Given this list of marker genes LRRC75A, ATXN2L, SLITRK3, ENHO, ZNF704, UBFD1, SPECC1L, METTL16, ULK2, ETV6, FGD1, CHST7, AGPAT1, RPP14, GSTCD, JADE2, RBFOX1, PRX, LGR4, KCNA7, TESK2, RBM14, SOX11, ITGA5, SUGP1, PSME3, CSNK1G1, ARID5A, TTC38, RSBN1L, SERTAD2, HAP1, SNRK, YWHAZ, WDTC1, ARID4B, PIM1, MAX, ZNF423, FOXO4, UBE2Z, ESCO1, ASAP1, NR3C1 (nuclear receptor subfamily 3 group C member 1), DDX11, DNMT3A, PNCK, H4C4, DYNC1I1, SEPTIN3, MECP2, CADM4, SLC2A1 (solute carrier family 2 member 1), H2AX, PTPN9, ARL4C, PLCB1, NRP2, VSIG4, TTYH3, DPH2, SLC39A5, EDARADD, ASB15, ZC3H12B, ST20-AS1, AFF2, USP37, GPM6A, SIX4, NRIP1, SCN2B, FAM133B, DPYSL3, ESRRA, SHISA5, PLAG1, PAK6, ST3GAL3, RPS29, here is a description of the gene set: Genes having at least one occurence of the motif AGGGCCA in their 3' untranslated region. The motif represents putative target (that is, seed match) of human mature miRNA hsa-miR-328 (v7.1 miRBase). species: Homo sapiens Human Gene Set: AGGGCCA_MIR328